The following is a description of a gene set: Human Gene Set: GSE27786_CD8_TCELL_VS_NKCELL_DN Each fraction of mouse hematopoietic cells was purified by cell sorting from bone marrow of 8-week-old C57BL/6 mice, and its gene expression was analyzed. Genes down-regulated in comparison of CD8 T cells versus NK cells. from publication Konuma T, Nakamura S, Miyagi S, Negishi M, Chiba T, Oguro H, Yuan J, Mochizuki-Kashio M, Ichikawa H, Miyoshi H, Vidal M, Iwama A (PMID 21540074) studied in species Homo sapiens, and this is the list of marker genes: ZBTB7B, FRRS1, PSAP, ARHGAP18, INHBA, EHMT2, GALNT9, TOR1AIP1, CEP126, SDC4, HSPA2 (heat shock protein family A (Hsp70) member 2), GEM, BAG3 (BAG cochaperone 3), SFT2D2, CCNA2, CMPK1, RNF157, RAB3GAP2, YIPF5, RNF19B, TRAK1, SERPINB8, PLEKHM3, WASF2, RIT1, ANXA3, MARVELD2, CHP1, CSRP2, FZD7, AXL, RAF1, NEDD9, ARHGEF2, RPL10, CHST1, ARHGAP19, SSR3, NFXL1, NKIRAS2, RFC2, ATXN1L, PLOD1, PCBD2, CFB, MFSD5, C9orf72, TMBIM6, BRI3, EIF4E3, HSD17B11, TRAFD1, TMBIM4, CITED4, LRP4, MPP1, ZNF326, GOLGA7, SLC4A7, CIP2A, PTPRJ, NFIX, IGF1, ULK1, PHACTR4, HMGN3 (high mobility group nucleosomal binding domain 3), LXN, TNS3, TMEM86A, PPT2, ERLIN1, PLSCR1, HPSE, TMEM38B, PLAC8, SCD, TMCC3, FBXO6, UGGT1, RB1, ABRAXAS2, ALDH2, ACADL, SNX13, ILRUN, KLF9, ZNF467, HOOK3, DSP, SEL1L, SLC6A6, NFKBIZ (NCBI Gene Id 64332), TBC1D24, CFL1, PEX19, PRKD3, CAPN15, OASL, CLEC10A, RTN3, CKB, DHRS3, CTNND1, SOD2, STK10, LRP2, OSBPL8, SNX9, IPMK, YWHAZ, SLC66A3, AP5Z1, MIR22HG, SPATA13, LTBR, TBC1D32, SEPTIN2, KCNK6, PHTF2, AAGAB, TNS4, ROPN1L, SNX2, PTTG1IP, ACYP2, PADI2, NEUROG2, CMIP, TMEM30A, PTAR1, DSTYK, PRKACA, RNPEP, CFP, TRIAP1, SLC43A3 (solute carrier family 43 member 3), ADIPOR2, TMEM179B, FAR1, CD84, CAMKK2, GSDMD, VPS9D1, KLC1, FFAR4, PRC1, ALPK1, ATP6V0B, CPQ, CAPZA1, ACTB, NXT2, TMED4, RAP2A, ANP32A (NCBI Gene Id 8125), TGFB3, CDCA5, VCPKMT, SLC46A3, AKAP7, CYBA, MBNL2, PIK3R6, LPCAT1, PRXL2B, SDF2L1, FRMD4A, EXOC6, SPIB, MAVS, MKNK1, NAA60, KIF13A, TSC2, MFSD14B, LIMS4, RBM47, DCTN4, ATOX1, ARID3A, HGF, UHRF1, CMYA5, VAMP3, KBTBD7, P2RY1, CUL1, FAM168A, HELB, ZMYND8, ANXA4, KIFC3, DYNLT3, CEP290, TRAM2, WDFY2 (NCBI Gene Id 115825), RPL39, LONRF3, GUSB, CLEC4D (NCBI Gene Id 338339)